The following is a description of a gene set: studied in species Homo sapiens Generation and organization of a platelet, a non-nucleated disk-shaped cell formed by extrusion from megakaryocytes, found in the blood of all mammals, and mainly involved in blood coagulation. Human Gene Set: GOBP_PLATELET_MORPHOGENESIS, and this is the list of marker genes: TUBB1, SRF, VPS33A, PTPN6, CLEC1B (C-type lectin domain family 1 member B), NBEAL2, ZFPM1, GATA1, MYH9, PTPRJ, TAL1 (NCBI Gene Id 6886), CASP3, MFAP2, ZNF385A, ACTN1, PTPN11, CASP9, EP300, BAP1, WDR1, CIB1, C1GALT1C1, TPM4, MPIG6B, MPL, MEF2C, PRKDC